Given this list of marker genes FBXW2, SHCBP1, ZFYVE1, BIVM, C9orf72, AMPH, NUMB, SRSF6, MED1, USP6, ZNF253, SEC23IP, ZNF649, IRAK1, CD80, FBXO4, MOCS2, CXXC4, VPS54 (VPS54 subunit of GARP complex), TCF20, ZNF662, CXADR, GATAD1, SAMSN1, TMEM19, CCK, ZNF652, COLEC10, VASN, ZNF506, HNRNPD, ARL10, ZNF367 (zinc finger protein 367), KCNJ16, CYP27B1, CTAGE8, SLC16A14, GRIA3, TOR1A, CTAGE4, ZNF493, RPF1, ZNF676, EIF4G2, SORT1, SIAH2, NOVA1, YWHAB, SLC10A3, CASP7, FLOT2, DCDC1, PLSCR4, YES1, C3orf38, ZNF540, LANCL1, LRRTM2, PPM1K, ZNF136, TRAF6, MRS2, WWC2, ZNF90, UPP2, HIPK3, BCORL1, THAP5, BRK1, FLNA, CTAGE9, DDHD1, PPP1R11, POFUT2, APPL1, LRP2, SLC12A6, CPM, ERBB4, PTPRA, ABL2, ZNF354B, NEB, BHLHE41, MAP3K8 (mitogen-activated protein kinase kinase kinase 8), NOS1, ZNF275, CNTF, NEMP1, ZNF257, TDRKH, MPHOSPH6, RHOBTB3, DCAF12, GDAP1L1, MBNL3, RARB, TMEM120B, ZBTB2, STRBP, MMP16, CCL5, PPBP, SRP72, GPM6B, USP32 (ubiquitin specific peptidase 32), CARD10 (caspase recruitment domain family member 10), C8orf88, SLC38A1, FZD1, LRCH1, MED20, SRD5A2, FOXR2, CD96, here is a description of the gene set: from publication Chen Y, Wang X (PMID 31504780) studied in species Homo sapiens Human Gene Set: MIR146B_5P Genes predicted to be targets of miRBase v22 microRNA hsa-miR-146b-5p in miRDB v6.0 with MirTarget v4 prediction scores > 80 (high confidence targets).